Given this list of marker genes SH2B2, GRP, PTGIS, LIPF, RCSD1, SUN2, CNTNAP1, CACNA1G, here is a description of the gene set: Estrogen-related receptors (ERRs) play critical roles in regulation of cellular energy metabolism in response to inducible coactivators such as peroxisome proliferator-activated receptor gamma (PPARgamma) coactivator 1alpha (PGC-1alpha). A yeast two-hybrid screen led to the identification of the cytokine-stimulated transcriptional regulator, Bcl3, as an ERRalpha coactivator. Bcl3 was shown to synergize with PGC-1alpha to coactivate ERRalpha. Chromatin immunoprecipitation studies demonstrated that ERRalpha, PGC-1alpha, and Bcl3 form a complex on an ERRalpha-responsive element within the pyruvate dehydrogenase kinase 4 gene promoter in cardiac myocytes. Mapping studies demonstrated that Bc13 interacts with PGC-1alpha and ERRalpha, allowing for interaction with both proteins. Transcriptional profiling demonstrated that Bcl3 activates genes involved in diverse pathways including a subset involved in cellular energy metabolism known to be regulated by PGC-1alpha, ERRalpha, and a second nuclear receptor, PPARalpha. Consistent with the gene expression profiling results, Bcl3 was shown to synergistically coactivate PPARalpha with PGC-1alpha in a manner similar to ERRalpha. We propose that the cooperativity between Bcl3 and PGC-1alpha may serve as a point of convergence on nuclear receptor targets to direct programs orchestrating inflammatory and energy metabolism responses in heart and other tissues. studied in species Rattus norvegicus Genes down-regulated in neonatal cardiac myocytes upon knockdown of BCL3 by RNAi. from publication Yang J, Williams RS, Kelly DP (PMID 19451226) Human Gene Set: YANG_BCL3_TARGETS_DN